Given this list of marker genes WNT7A (Wnt family member 7A), SMARCAL1, WNT3, FGFR3, CEP120, ERCC6, OBSL1, CCDC8, CUL7, COMP, NSDHL, POC1A, PORCN, RSPO2, ERCC8, COL2A1, here is a description of the gene set: Human Gene Set: HP_HYPOPLASTIC_PELVIS Underdevelopment of the bony pelvis. species: Homo sapiens Hypoplastic pelvis